Given this list of marker genes Mcemp1, Stat5a, Rac2, Kit, Il3 (NCBI Gene Id 16187), Enpp3, Lyn, Nf1, Stat6, Kitl, here is a description of the gene set: species: Mus musculus The expansion of a mast cell population by cell division. Mouse Gene Set: GOBP_MAST_CELL_PROLIFERATION